The following is a description of a gene set: Binding to interleukin-11. studied in species Mus musculus Mouse Gene Set: GOMF_INTERLEUKIN_11_BINDING, and this is the list of marker genes: Il6ra, Il11ra1, Cntfr, Il6st, Il11ra2